Given this list of marker genes Cd36, Dlg1, Zfp382, Zeb1, Ten1, Hbb-bh1, Hcfc2, Chek1, Zbtb33, Zbtb45, Mesp1, Med25, Wdr82 (WD repeat domain containing 82), Nr2f1, Pdcd4, Ifi27 (interferon, alpha-inducible protein 27), Smtnl1, Fbxw11, Men1, Ercc6, Igf2, Atf7, Pcgf2, Rara, Hdac2, Jdp2, Xrcc5, Cnot2, Rbbp4, Shld3, Zfp438, Zic2, Ascl2, Sox3, Foxp2, Prrx1, Mnt, Tnfsf11, Zfp239, Sap18, Zfpm1, Slfn1, Cnot7, Dkc1, Pfdn5, Nrg1, Nr4a3, Traf2, Relb, Pabpc1 (poly(A) binding protein, cytoplasmic 1), Chd8, Pkia, Ctcf, Maged2, Maz, Arid4b, Hes2, Lhx9, Zbtb18, Mageb11, Myb, Gdnf, Sgms1os1, Tpr, Mcrs1, Zp3, Birc5, Lpin1, E4f1, Rnps1, Wdtc1, Sox21, Tshz3, Gja1, Prdm16, Mtor, Ankrd1, Rad50, Sfswap, H3c14, Suz12, Otub1, Hjv, Srsf6, Spindoc, Blm, Fnip1, Hmga1 (high mobility group AT-hook 1), Xrcc4, Zfp703, Bmp7, Ilf3, Dynll1, Scx, Csde1, Pitx2, Dnajb6, Nfatc2, Irf2bp2, Nkx6-2, Zfp386, Suv39h2, Mxd1, Ppm1f (NCBI Gene Id 71214), Rcor2, Hes1, Hsf5, Dap, Ing1, Nfe2l1, Pax2, Foxp4, Atf2, Gsc, Tent5b, Gata3 (GATA binding protein 3), T (NCBI Gene Id 20997), Nr2c1, Ybx2 (Y box protein 2), Pou6f1, Srsf7, Zc3h8, Zranb3, Hipk3, Keap1, Crebzf, Ppp2ca, Cux2, Srebf2, Sox6, U2af2, Smyd1, Nfkb1, Foxq1, Nkx2-1, Ikzf4, Hnrnpa0, Zfp3, Kctd15, Tal1, Sqstm1, Ahr, Rnf168, Wwtr1, Otud7b, Mup4, Etv6, Notch2, Nr2c2, Mre11a, Shc1, Eomes, Mup2, Esx1, Taf7, Klhl15, Bach2, Phax, Ywhab, L3mbtl3, Sars1, App, Eif4enif1, Smarce1, Rbfox2, Scaf8, Igf2bp1, Fnip2, Tenm2, Magee1, Tceal7, Shld1, Cry2, Apbb2, Rorb, Mta1, Ferd3l, Sfpq, Sumo2, Pramel7, Flywch1, Phc3, Ccnd3, Thra, St18, Gatad2a, Vgll4, Magea10, Dnmt3b, Rbm46 (NCBI Gene Id 633285), Prdm2, Pou4f1, Phf21a, Nedd4, Supt4a, Lilrb4a, Nr4a2 (nuclear receptor subfamily 4, group A, member 2), Cbfa2t3, Batf3, Mbd3, Irx2, Ascl5 (achaete-scute family bHLH transcription factor 5), Tob1, Noct, Magea8, Xrcc6, Ezh1, Creb3l1, Cdk2, Cenpf, Dlx1, Pramel1, Mxi1 (NCBI Gene Id 17859), Zglp1, Pgk1, Hexim1, Ikbke, Sox5, Mxd4, H1f10, Klf10, Smyd2, Hamp, Cited1, Ago2, Rfc1, Ptbp1, Dhx36, Kdm2a, Meioc (meiosis specific with coiled-coil domain), Cryab, Hspa1a, Nr6a1, Ifi203, Zbtb24, Ehmt2, Slirp, Tcf4, Bmp2, Sirt1, Git1, Olig2, Terf1, Sall2, Epas1, Cdkn2a, Gnl3l, Abl1, Stat1, Eng, Ccdc85b, Kctd1, Hsf1, Nfib, Rreb1, Rybp, Zbed6 (zinc finger, BED type containing 6), Srsf9, Commd7, Nfatc4, Zfp354c, Mapk10, Stat3 (NCBI Gene Id 68733), Cir1, Dcp2, Tfap2b, Nupr2, Rbm15b, Hoxd8, Ier3, Atm, H1f2, Hes3, Tent5d, Dubr, Ripply1, Myd88, Nsmce3, Mbip, Gm4924, Zbtb6, Smarcc2, Ywhaz, Magel2, Raly, Secisbp2, Gm4275, Nab2, Bend3, Sfn, Pcbp4, Tfap2a, Tspyl2, Mageb18, Rxra (NCBI Gene Id 78740), Rhox3a, Fus, Trps1, Recql5, Dr1, Hopx, Zmym2, Rbbp7, Pparg, Pinx1, Met, Loxl3, Rad18, Lrpprc, Hr, Uhrf1, Mettl16, Pou3f1, Ezr, Mbd3l1, Ascl1, Gmnn, Foxg1, Hdac4, Stat6, Kank2, Slfn2, Sumo1, Bptf, Wdr5, Zbtb5, Nr2e1, Parp9, Cdyl, Hdac9 (histone deacetylase 9), Egr1, Nck1, Dhrs7b, Dnajb1, Mageb2, Elf2, Atf3 (activating transcription factor 3), Myc, Zfp90, Zfp932, Irx1, Celf4, Cic, Purb, Naf1, Atn1, Mndal, Pura, Drap1, Klf7, Shld2, Zhx3, Hexim2, Phb1 (NCBI Gene Id 18673), Cela1, Zhx1, Cnbp, Kdm5b, Traf5, Nkx6-1, Amdhd2, Zfhx3, Calr, Suds3, Kat5, Sp100, Dazl, Cys1, Phf14, Glis3, Rb1, Nelfe, Zbtb46, Mageb5, Rlim, Hdac3, Rnf169, Mcph1, Rcor1, Hmga1b, Pid1, Boll, Tasor, Zbtb7a, Ptprk, Zbtb7b, N4bp2l2, Angel2, Tirap, Kdm2b, Kat14, Rsl1, Hmga2, Prdx5, Flna, Ybx3, Sfmbt2, Mideas, Nipbl, Smarca5, Magee2, En1, Heyl, Hoxa2, Ovol2, Cited2 (NCBI Gene Id 17684), Ncor1 (NCBI Gene Id 320690), Tnfsf4, Irx4, Foxp3, Nkx2-5, Jun, Gtpbp4, Klf12, Hoxc8, Ppargc1b, Axin1, Dusp5, Dnmt3l, Nkx3-2, Hnrnpc, Cry1, Tcf3, Pou4f2, Fxr1, Xcl1, Taf3, Glis2, Sap18b, Zfp418, Gmppa, Zbtb16, Zfp148, Dusp22, L3mbtl1, Magec2, Xrcc1, Lrrfip1, Rpl10, Bclaf1, Atf5, Myt1l, Wwp2, Zbtb8a, Rorc, Foxd3, Nr1i3, Ezh2, Setdb1, Sox1, Magea4, Scml4, H1f0, Rcor3, Dffb, Tcerg1, Ripply2, Foxk2 (forkhead box K2), Elk3, Pkp3, Foxc2, Magea14, Lhx1, Hivep1, Nfix, Rela, Trim24 (NCBI Gene Id 352987), Zc3h6, Jund, Id2, Zfp397, Mettl13, Nr1h4, Dab2ip, Psen2, Sp3, Tipin, Fam220a, Zmynd15, Pou3f3, Isl1, Foxr1, Tcp10b, Gzf1, Nr1d2, Vip, Foxa2, Dicer1, Ptch1, Kdm5a, Sim2, Fbxo5, Cbx2, Nsun2, Ddit3, Mdfi, Cbx1, Pex14, Snai2, Atp5if1, Dusp1, Foxf2, Fbh1, Mdm4, Uimc1, Mtch2, Brd7, Nr1h2, Zfp24 (zinc finger protein 24), Tbx21, Kat2a, Hbp1, Trim29, Wfs1, Zfp217, Mecom, Pou5f1, Zfp973, Ralgapa1, Akr1c6, Mup11 (major urinary protein 11), Foxh1, Id4, Zfp354b, Aebp1, Tbx2 (NCBI Gene Id 21385), Gata5 (GATA binding protein 5), Clock, Tbl1xr1 (NCBI Gene Id 99912), Riox1, Runx3, Gli2, Trim37, Esrrb, Fezf1, Hes5, Zfp451, Apobec3, Cirbp, Basp1, Ccar2, Tbx6, Halr1, Msc, Hdgf, Fasl, Bmp4 (NCBI Gene Id 12159), Nfatc1, Ddx54, Setdb2, Cnot1, Zfp827, Cdc73, Zbtb26, Esrra, Hoxa7, Pias4, Dcaf1, Ppid, Shh, Skor1, Ogt, Ifng, Mageb4, Bcl11a, Bin1, Rgn, Eid2, Irx3, Scml2, Mageb5b, Zbtb49, Rasd1, Aebp2, Mef2c, Maged1, Nelfcd, Zfp423, Phf19, Pasd1, Ehmt1, Tcf7l2, Csnk2a1, Tbx3, Mettl1, Mnx1, Samd11, Akirin2 (NCBI Gene Id 67185), Sap25, Eid2b, Mageh1, Msx1, Hinfp, Bmp6, Ube2i, Mapk15, Foxk1, Foxc1, Paf1, Actn3, Klf2, Traf3ip1, Zbtb25, Morc2b, Traf3ip2 (TRAF3 interacting protein 2), Gtf2ird1 (general transcription factor II I repeat domain-containing 1), Max, Sox15, Nfe2l3, Zfp263, Plk1, Msh6, Cda, Insm2, Olig3, Six1, Loxl2, Slc4a1, Rpl10-ps3, Larp7, Zfp503, Thap11, Cpeb3, Hsbp1, Prkn, Six3, Sox8, Hba-x, Sox13, Dkk3, Tent4a, Radx, Btg2, Btaf1, Wt1, Sirt6, Kdm1a, Foxp1 (forkhead box P1), Trib3, Maf, Cdk6, Fgfr1, Ddx5, Pml, Ifi213, Yy1 (NCBI Gene Id 22632, YY1 transcription factor), Nono, Zscan10, Paip1, Ifi207, Zfp473, Sp5, Ikzf1, Phc2, Hnrnpl, Esr2, Msh2, Ovol1, Srf, Nfatc3 (NCBI Gene Id 97460), Rbm42, Ttf1, E2f8, Pou2f1, Trim66, Nelfa, Prdm12, Eno1b, Tent5c, Cipc, Sox14, Foxa1, Mkx, Parpbp, Pcgf1, Zfpm2, Phb2, Rfx3, Dach1, Zbtb10, Insm1, Hdac10, Usp3, Rbm15, Thap7, Rbbp8 (NCBI Gene Id 225182), Foxj1, Cbx8, Zfp653, Ar, Nsd2, Rsf1 (NCBI Gene Id 77334), Cdkn1b, Prnp, Pcna, Neil1, Barx2, Nfkbie, Tada3, Rps3, Ripply3, Lims1, Rnf8, Upf3a, Nelfb, Cbx3, Rnf2, Zc3h4, Magea1, Rbm20, Tcf7l1, Dyrk1a, Nsd3, H1f9, Six5, Foxo1, L3mbtl2, Prdm8, Klf5, Mxd3, Hipk1, Tcf7, Zmynd11, Srsf1, Rbm38, Rrp8, Wtip, Mageb3, Snai3, Mageb6b1, Gadd45a, Sla2, Gli3, Supt5, Larp7-ps, Ets2, Txnip, Glis1, Ctc1, Sox7, Lefty1, Nfx1, Csf2, Sall1, Osr1, Helb, Cul3, Tcfl5, Tle4, Wnt4, Ifi209, Hdac7, Per1, Nbas, Zbtb42, Zmym5, Zfp469, Nr1h5, Dlx2, Zhx2, Baz2a, Wapl, Terf2, Pa2g4, Ctbp2, Atr, Nsd1, Fezf2, Bcor, Uba3 (NCBI Gene Id 319310), Zfp125, Cdx2, Cbx4, Prdm1, Nrip2, Ascl3, BC037156 (NCBI Gene Id 494497), Dnd1, Tinf2, Scmh1, Strn3, Pax4, Dnmt3a, Twist1, Jarid2, H1f1, Gpi1, Pax5, Scaf4, Zc3h14, Tfap4, Efna1, Ciart, Mecp2, Zbtb37, Dnaja3, Npas1, Wwc1, Atoh8, Id1, Mier2, Smo, Ddit4, Impact, Src, Neurog3, Smad5, Crebrf (NCBI Gene Id 77128), Tmprss6, Ywhaq, Tsc22d4, Bhlhe40, Mafk, Sgf29, Nkrf, Foxm1, Notch3, Prmt5, Rest, Tnp1, Hhex, Magea6, Gas6, Gabpa, Hmg20a, Gps2, Nat10, Slc11a1, Psmd10, Nr2f6, Txn1, Zfp111, Fgf9, Cbfb, Ankrd2, Tgfb1, Apobec1, Irak1, Rd3, Mmp12, Klf16, Pax6, Myoz2, Jph2, Adipoq, Zfp777, Peg3, Tgif1, Nicol1 (NCBI Gene Id 381633), Il33, Myoz1, Limd1, Dffa, Aldob, Rtel1, Pot1a, Acin1, Nscme3l, Cbx5, Patz1 (NCBI Gene Id 80645), Flcn (NCBI Gene Id 216805), Zfp512b, Pfkfb1, Hoxd9, Noc2l, Lmo1, Hnf1b, Rbm47, Spdef, Pif1, Pbxip1, Tsg101, Irf8, Lilrb4b, Trim11, Pax9, Arid4a, Dnajc2, Fam76b, Kat6a, Fbln5, Supt4b, Lmcd1, Nmnat1, Nr3c1, Vhl, Magea13, Thrb, Tbx1, Uxt (ubiquitously expressed prefoldin like chaperone), Sirt2, Zfp36, Taf15, Zbtb2, Sry, Esr1, Ifi214, Otp, Drd3, Stn1, Kmt5a, Wnt10b, Nr1i2, Amot, Zfp219, Tfdp2, Trp63, Mbd1, Tle1, Tcp10a, Spen, Tardbp, Mtdh, Sik2, Deaf1 (DEAF1, transcription factor), Pias1 (protein inhibitor of activated STAT 1), Rpl23, Sema4d, Npm1, Nkx3-1, Bhlhe22, Tnks2 (NCBI Gene Id 74493), Cbfa2t2, Mier1, Ncor2, Nr1d1, Cebpd (CCAAT/enhancer binding protein delta), Trp53, Kat6b (NCBI Gene Id 54169), Zfp541, Notch1, Mzf1, Rarb, Cxxc5, Hoxb13, Senp3, Nr0b2, Hnrnpu, Prmt2, Psmc5, Il4, Uri1, Terf2ip, Ccne1, Thrap3, Phc1, Lbh, Foxl2, Enpp7 (NCBI Gene Id 404708), Brca1, Tent2, Fgfr2, Hspa8, Hipk2, Cggbp1, Hbb-y, Zgpat, Ptpn2, Ifi206, Fgfr3, Tnf, Ifi208, Sox11, Satb2, Mlx, Pde2a, Mphosph8, Mlh1, Hoxb4 (NCBI Gene Id 15412), Bcorl1, Yeats2, Smad2, Tbl1x, Macroh2a1, Zfp57, Vsx2, Zfp608, Klf3, Exosc10, Cdk5, Fbp1 (NCBI Gene Id 14122), Zfp536, Irf1, Cdt1, Nudt16, Zfp748, Ctbp1, Srsf10, Ddx20, Dhx34 (DExH-box helicase 34), Bmi1, Prdm11 (NCBI Gene Id 278932), Ift172, Sall4, Elk4, Pawr, Hmgn2, Ppard, Klf8, Ing4, Mta2, Tspo, Mlip, S100a1, Foxo3 (NCBI Gene Id 97633), Dhx9, Pole3, Yaf2, Zbtb12, Ylpm1, Brms1, Isx, Acd (NCBI Gene Id 497652), Hnrnpab, Wnt11, Casp8ap2 (caspase 8 associated protein 2), Fancb, Coq7, Trdmt1, Rps6ka5 (NCBI Gene Id 73086), Foxn3, Arid5a, Gbp4, Tet1, Nog, Hcfc1, Macroh2a2, Zfp175, Cebpa, Igf2bp2 (insulin-like growth factor 2 mRNA binding protein 2), Cdx4, Dmbx1, Zmynd8, Sox18, Sp2, Niban2, Rarg, Setd5, Asxl2, Oog2, Scrt1, Satb1, Ikzf5, Suv39h1, Prdm14, Atxn1l, Samd1, Aicda, Nrde2, Zfp281, Cd38, Bcl3, Dedd, Eed, Mef2a, Zfp488, Zfp568 (NCBI Gene Id 97388), Crym, Zbtb34, Ahrr, Tigar, Mbd2, Snai1, Kdm4a, Tle5, Pitx1, Tmbim6, Eid1, Crebbp, Bach1, Mir7-1, Crem, Hcls1, Rere, Morc2a, Il17a, Inppl1, Ptprc, Pspc1, Myf6, Phf12, Trpv4, Hesx1, Epo, Ppp1r13l, Pax3, Il1b, Zfp1006, Gata1, Sox12, Ighmbp2, E2f1 (NCBI Gene Id 13555), Tcf25, Mdm2, Cgas (NCBI Gene Id 214763), Trp53bp1, Bmyc, Hoxb3, Parp3, Entpd1, Irf2bp1, Rbpj, Tgif2, Zfp202, Mbtd1, Zfp13, Hmbox1, Trerf1, Zscan4c, Zbtb20, Grem1, Oog3, Skil, Gatad2b, Cdkn1c, Acvr2b, Brms1l (NCBI Gene Id 71698), Zfp366, Snx6, Hey1, Aurkb, Elavl1, Nudt16l1, Hey2, Timeless, Gon4l, Bend5, C1d, Scrt2, Myog, Sbno2, Wwp1, Klf4, Trim63, Larp1, Hcrt, Per3, Morc3, Id3, Xbp1, Msh3 (NCBI Gene Id 17686), Ppargc1a, Thap1, Mitf, Six4, Igf2bp3, Dnmt1, Zbtb38 (NCBI Gene Id 245007), Ednrb, Pcgf6, Rhox5, Ldb2, Kcnk2, Bap1, Syncrip, Dact1, Mup3, Map2k5, Edn1, Zfp706, Ogg1, Nr2e3, Tgfbr1, Dmrt1, Ptbp3, Atxn1, Pcbp3, Hmx1, Tsix, Sorbs3, Tbx18, Zfp639, Mup5 (NCBI Gene Id 17844), Zfp174, Zfta, Mybbp1a, Hnf4a, Atf4, H1f5, Zfp746, Ppara, Ring1, Tcp10c, Dnajb5 (NCBI Gene Id 68759), Epc1, Trim6, Ptgs2os, Larp4b (La ribonucleoprotein 4B), Vax1, Plk3, Dnajc17, Nupr1, Vax2, A430033K04Rik, Ep300, Zfp128, Zcchc17, Dusp15, Mir466l, Morc1, Zbtb1, Zfp958, Wnt5a, Vegfa, Hdac5 (NCBI Gene Id 15184), Bmal1, Nfic, Zfp819, Ins2, Ccnd1, Hes6, Sdcbp, Bend6, Nif3l1, Tent5a, Gclc, Mterf3 (NCBI Gene Id 66410), Maf1, Rbmxl1, Nkap, Nab1, Smad3, Nfkbia, Snw1, Hnrnpk, Zbtb21, Nanog, Mdfic2, Rad17, Bcl6, Nkx6-3, Ywhaq-ps3, Rhox2a, Ereg, Sirt7, Inpp5k, Gfi1, Phf6, 5730507C01Rik, Ercc1, Lancl2, Riox2, Cebpb, Trim28, Dab2, Pkp1, Ncoa2, Arid5b, Oog1, Sox4, Tnks, Hif1a, Mettl14, Pphln1, Rmi2, Ppp1r15a, Smchd1, Fabp4, Sox10, Tle2, Smarca4, Cops2, Map3k10, Ctr9, Prickle1, Cc2d1b, Cav1, Fst, Mynn, Hand1, Hsbp1l1, Alx1, Magea5, Lcor, Hmgb1, Magea2, Mael, Ankle1, Kat8, Lep, Per2, Sox9, Sap30l, Apbb1, Frk, Nr2f2, Polq, Eno1, Bahd1 (NCBI Gene Id 99388), Znhit1, Zar1, Zfp809, A1cf, Gata4, Zbtb32, Ubqln4, Tle6, Dll4, Dnajb4, Tro, Irf2bpl, Zfp735, Fzd1, Ski, Sox2, Pds5a, Hic1, Psen1, Prkaca, Sik1, Capn3, Taf9b, H1f4, Spi1, Irx6, Lef1, Hsf4, Prmt6, Prdm5, Foxs1, Nr1h3, Vdr, Sinhcaf, Helt, Qki, Tbr1, Tbx20, Msx2, Zeb2, Zfp354a, Ndufa13, Notch4, Tcf23, Smarca2, Pdx1, Fhl2, Pdgfb, Amotl2, Tagln3, Atg7, Nacc2, Sox30, Tbx22, Sufu, Mospd1, Zfp658, Skor2, H1f3, Elf3, Cdkn1a, Mepce, Med1, Yap1 (yes-associated protein 1), Atf7ip, Gzma, Lyar, Zfp683, Spop, Cyren (cell cycle regulator of NHEJ), Sap30, Rtf1, Klf11, Prdm13, Nepn, Cbx6, Mup1, Traf7, Sfrp2, Magea9, Prdm6, Ndfip1, Smad4, Qars1, Nppc, E2f6, Jazf1, Kat2b, Mta3, Mapkapk2, Foxe1, Strap, Tfec, Chd3, Chd5, Plcb1, Ruvbl2, Nrarp, Setmar, Ldb1, Hnf1a, Atp8b1, Hes7, Nop53, Cbx7, Bag4, Gata2, Npat, Tcf21, Ifi203-ps, Xpo1, H1f8, Rbm24 (NCBI Gene Id 76176), Btrc, Fis1, Setd7, Elane, Zfp715, Slx4, Tnfrsf4, Aunip, Tbx15, Khdrbs1, Rbl1, Pot1b, Nr0b1, Zbtb39, Bcl6b, Kdm8, Foxd1, Ccar1, Mypop, L3mbtl4, Usp47, Hnf4aos, Fcor, Sin3a, Smad7, Runx2, Gata6, Sarnp, Elavl4, Msx3, Srsf4 (serine and arginine-rich splicing factor 4), Hdac1, Zbtb14, Arid1a, Zbtb4, Usp2, Creb1, Nodal, Zfp318 (NCBI Gene Id 78588), Myocd, Shox2, Sfmbt1, Cmtm2a, Srebf1, Actrt1, Tfcp2l1 (transcription factor CP2-like 1), Dmap1, Osr2, Pwp1, Ercc4, Parp1, Prop1, Traf6, Hif1an, E2f7, Rbm10, Sin3b, Scai, Sfrp1, Twist2, Zkscan3, Myef2, Sdr16c5, Samd7 (NCBI Gene Id 75953), Cdk5r1, Rif1, Ndn, Hmgb2, Etv3, Tdg, Zfp616, Dkk1, Klf17, Dlx4, Ing2, Cux1 (cut-like homeobox 1), Ctnnbip1, Depdc1a, Mier3, Nrip1, Nfil3, Ctnnb1, Tent4b, Arx, Mlxipl, Kcnip3, Kdm5c, Nacc1, Wwc2, Runx1t1, Ciita, Ajuba, Axin2, H1f6, Cby1 (chibby family member 1, beta catenin antagonist), Lig3, Zfp12, Parn, Zfp692, Lmo4, Eapp, Nck2, Pou1f1, Cc2d1a, Sub1, Foxf1, Hnrnpa2b1, Dusp26, Magea3, Smg6, Glrp1, Actr6, Hnrnpd, Zfp668, Scgb1a1 (secretoglobin, family 1A, member 1), Trim27, Apbb3, Zfp296, Ybx1, Nbn, Mbd3l2, Nostrin, Sap130, Zfp131, Lin37, Pkig, Runx1, Ern2, Mdfic, Muc1, Mad2l2, Rps14, Daxx, Mageb16, Zfp750, Prox1, Hoxb8, Rfx5, Chd4, Trpv1, Pias3, C1qbp, Bhlhe41, here is a description of the gene set: Any cellular process that stops, prevents, or reduces the frequency, rate or extent of the chemical reactions and pathways involving nucleobases, nucleosides, nucleotides and nucleic acids. Mouse Gene Set: GOBP_NEGATIVE_REGULATION_OF_NUCLEOBASE_CONTAINING_COMPOUND_METABOLIC_PROCESS species: Mus musculus